Given this list of marker genes Ptpn2, Tnfaip8l2, Dnase1, Ighg1, Mmp8, Nr5a2, Nlrp4e, Isl1, Kars1, Socs3, Gper1, Ctsc, Trim65, Cd200r2, Bcl6b, Mcph1, Mvk, Nlrp9a, Alox15, Cd47, Stap1, Adora1, Fpr-rs6, Pbk, Casp4, Il20rb, Il4, Zdhhc5, Mdk, C3, Nlrp5, Napepld, Gpr4, Il17rb, Grn, Ndfip1, Daglb, Il17ra, Clec12a, Tnf, Igtp, Bap1, Shpk, Adora2a, Lpcat3, Nr1d1, Nlrp4b, Fpr-rs7, Trpv4, Rora, Ins1, Cebpb (CCAAT/enhancer binding protein beta), Calhm2, Ttbk1, Cd200r4, Dagla, Ada, Selenos, Cnr1, Ier3, Celf1, Ccl5, Rictor, Ghsr, Ptges, Lgals2, Park7, Abr, Il22ra2, Socs5, Slc39a8, Cebpa, Pla2g2d, Cd200l2, Nlrp1b, Fem1a (NCBI Gene Id 14154), Abhd12, Reg3a, Tyro3, Gps2, Cd81, Gpr17, Psmb4, Dnase1l3, Sucnr1, Git1, Trim45, Il2ra, Nod2, Nr1d2, Il10, Wfdc1, Tlr6, Ggt1, Lrrk2, Abcc1, Foxp1, C2cd4a, Ccl3, Fpr-rs4, Pglyrp2, Cx3cr1, Lrfn5, Sirpa, Csf1r, Spn, Slamf8, Pik3ap1, Duoxa1, S100a9 (S100 calcium binding protein A9 (calgranulin B)), Mfhas1, Reg3g, C2cd4b, Ddt, Nfkbiz, Ccr7, Cyp19a1 (NCBI Gene Id 13075), Fcgr1, Ccr5, Il1rl2, Gm12250, Ahsg, Pla2g10, Adora2b, Foxf1, Fcer1a, Ccn4, Muc19, Alox5, Tlr9, Lpl, Il12b, Nmi, Gsdmd, Ripk1, Cx3cl1, Gpx1, Pparg, Il6, Arel1, Stat3, Bcr, Ighg2b, Nlrp10, Fem1al, Gprc5b, Nr1h3, Irf3, Ins2 (NCBI Gene Id 16334), Scgb1a1, Tnfaip6, Irgm2, Ppara, Fcer1g, Setd4, Sting1, Ncf1, Otulin, Hamp, Ets1, Rela, Ifnb1 (interferon beta 1, fibroblast), Aoah, Gbp3, Pde5a, Nlrp14, Syt11, Tslp, Serpine1, Pde2a, Tnfsf4, Cd276, Siglecg, Gbp2, Cd200, Mefv, Ccl1, Sod1, Cma1, Gpr31b, Lgals1, Duoxa2, Nlrp4c, Pycard, Pdcd4, Stat5b, Nr1h2, Tafa3, Adamts12, Gstp1, Nfkb1, Ctla2a, Nlrc3, Stat5a, Casp3, Myd88 (myeloid differentiation primary response gene 88), Armh4, Tff2, Nppa, Pik3cg, Il22ra1, Sphk1, Nfe2l1, Igf1, Foxp3, Vps35, Letmd1, C1qtnf3, Htr2a, Gbp2b, Tnip1, Ghrl, Uaca, Mas1, Nlrp3, Cd200r1, Drosha, Alox5ap, Nr1h5, Fbxl2, Nlrp2, Cdh5, Lrrc19, Il2, Gata3, Sema7a, Bcl6, Dhx9, Pdcd10, Proc, Aim2, Zdhhc9, Casp1, Fxr1, Nlrp12, Cxcl17, Vamp8, Fpr2, Rhbdd3, Btk, Snca, Tbc1d23, Fancd2, Ppard, Cd44, Gbp5, Cst7, Nlrp6, Agt, Nlrp4f, Tlr2 (NCBI Gene Id 24088), Il33, Tnfaip3, Nlrx1, Pla2g5, Dusp10, Pglyrp1, Tmsb4x (NCBI Gene Id 19241), Mkrn2, Tnfrsf11a, Prkca, Nlrp1a, Tradd, Ahr, Ldlr, Fut7, Macir, Fanca, Chrna7, Nlrp9b, Cyld, Fpr-rs3, Metrnl, Ifng, Acp5, Stk39, Ptpn6 (protein tyrosine phosphatase, non-receptor type 6, NCBI Gene Id 15170), Irgm1, Trem2, Ppp1r13l, Bst1, Kcnn4, Siglece, Ager, Hgf, Pmp22, Lilra5, Spata2, Mir7578, Ccr2, Ptger3, Nfkbia, Ptgis, Dsg2, H2-T23, Il22b, Nr1h4, Adcyap1, Lgals9, Pla2g3, Acod1, Adam8, Setd6 (NCBI Gene Id 66083), Mir147, Ash1l, Rb1, Npy, Trex1, Aoc3, Atm, Jak2, Elf4, Adora3, Cd200r3, Il17a, Hyal2, Fndc4, Ffar3, Il16, Apoe, Pf4, Lacc1, Arnt, Apoa1, Osm, Nlrp9c, Gpx2, Fabp4, C1qtnf12, Sharpin, Nt5e, Il18, Npy5r, Fam76b, Il22, Ufl1, Rps19, Camk2n1, Usp18, Nlrp4a, F12, Sbno2, App, Ido1, Psma1, Clock, Plcg2, Gpsm3, Fcgr3 (Fc receptor, IgG, low affinity III), Il13, Il10ra, Mgll, Adipoq, Casp12, Clcf1, Brd4, Tac1, Slc7a2, Ccn3, Esr1, Zbp1, Tlr4, Lbp, Rabgef1, Il1r1, Lta, Sbno1, Hspa4 (heat shock protein 4), Wnt5a, Tnfsf18, Cd24a, Tnfrsf1b, Ninj1, Krt1, Dicer1, Ednrb, Ptgs2, Ifi35, Fcgr2b, Smad3, S100a8, Tnfrsf1a, Lyn, Zp3, Ffar4, Nupr1, Map3k8, Cd200l1, Il1b, Ptger4, Tgfb1, Anxa1, Ccl24, Zfp36, Tnfsf11, Cd28, Snx4, Xcl1, Nkg7, Smpdl3b, Akna, Enpp3, Ctss, Extl3 (NCBI Gene Id 78404), Il1rl1, Ffar2, Tnc, here is a description of the gene set: Mouse Gene Set: GOBP_REGULATION_OF_INFLAMMATORY_RESPONSE species: Mus musculus Any process that modulates the frequency, rate or extent of the inflammatory response, the immediate defensive reaction (by vertebrate tissue) to infection or injury caused by chemical or physical agents.